The following is a description of a gene set: A ribonucleoprotein complex that catalyzes cleavage of the leader sequence of precursor tRNAs (pre-tRNAs), generating the mature 5' end of tRNAs. Mouse Gene Set: GOCC_RIBONUCLEASE_P_COMPLEX studied in species Mus musculus, and this is the list of marker genes: Pop7, Rpp25 (ribonuclease P/MRP 25 subunit), Hsd17b10, Trmt10c, Rpp21, Pop4, Pop5, Prorp, Rpp38, Rpp40, Rpp14, Rpp30, Pop1